The following is a description of a gene set: Hypertriglyceridemia species: Homo sapiens Human Gene Set: HP_HYPERTRIGLYCERIDEMIA An abnormal increase in the level of triglycerides in the blood., and this is the list of marker genes: MAGEL2, LDLRAP1, BSCL2, SLC7A7 (solute carrier family 7 member 7), ABHD5 (NCBI Gene Id 51099), ABCA1, CELA2A, FOS, LIPA, GPD1, ALMS1 (NCBI Gene Id 7840), NPAP1, STXBP2, PSMB8, MC4R, LRP6, TBCK, GPIHBP1, UNC13D, LZTFL1, LPL, SAR1B, LEP, LIPE, EMD, PIGT, SNORD115-1 (small nucleolar RNA, C/D box 115-1), APOC2, BBIP1, DEF6, ASL, MKS1, TTC8, PYGL, DYRK1B, BBS12, BBS10, SLC25A13, PLAAT3 (phospholipase A and acyltransferase 3), TMEM43, APOB, WDPCP, POLR3A, CEP290, LEPR, TNFRSF9, CAV1 (caveolin 1), SNORD116-1, SLC2A2, SYNE1, FLII, BBS7, PIK3CG, BBS5, SDCCAG8, IQSEC2, AIP, LYST, JAG1, MKRN3, CAVIN1, PNPLA2, PPARG, CFAP418, FHL1, LCAT, APOA5, YARS1, FECH, AEBP1, POLD1, PWAR1, PHKA2, IFT172, LMNA, HERC2, EXTL3, IFT27, PIGH, ADCY3, SLC37A4, PRF1, STX11, AKT2, SLC19A1, PHKB, ARL6 (NCBI Gene Id 84100), MKKS, AGL, BBS2, SCAPER, NSMCE2, MTX2, PHKG2, PSMB4 (NCBI Gene Id 5692), LIPC, SCLT1, RSPO1, BBS4 (NCBI Gene Id 585), DEAF1, CIDEC, RAI1, GPR101, PCYT1A, SGPL1, APOE, LMF1, CEP19, BBS9, MCM10, PLIN1, AGPAT2 (1-acylglycerol-3-phosphate O-acyltransferase 2), ADRA2A, SMPD1, CYP7A1, PLVAP, GK, HAVCR2, TRIM32, WRN, PWRN1, XRCC4, TTPA, SLC29A3, BBS1, XIAP, NPHP1, CREB3L3, PSMB10 (NCBI Gene Id 8138), FARSA, SYNE2, IFT74